Given this list of marker genes DUSP10, COL4A4, TRIM45, ADCY6, TTLL7, TIPIN, NCOA7, PLCXD1, MSH2, TCEAL9, E2F2 (E2F transcription factor 2, NCBI Gene Id 1870), SVIP, CLSPN, INSR, ABCA5, ZBTB14, PRIM1, RGS7, MCM10, C1GALT1, RFC2, EZH2, IVNS1ABP (NCBI Gene Id 51489), RECQL4, TOPBP1, CCN2, PCNA, NR4A3, CDC25A, H3C2, CNNM3, H4C5, DLGAP1, OSBPL6, ATAD2, TNS2, MSH6, DTL, CDT1, TLR3, PTGS2, PLSCR4, DNAJC6, PANK2, CCNE2, ACYP1, DNAJC3, RPA2, WDR76, MNS1, E2F1, DCLRE1A (DNA cross-link repair 1A), CDH24, RAD51, RABIF, SLC25A27, OSGIN2, GK, ZNF367, RRM2, MNX1, MNT, MDM1, ZMYND19, RBBP8, LIPH, MCM2, MBNL2, H2BC4, RFXAP, POLE, YEATS4, TENM3, MCM3, NEDD9, SPIN3 (NCBI Gene Id 169981), SMPD1, UBR7, MCM6, HSPB8, TCF19, RFC4, EAF2, POLE2, ARGLU1, FST, KLF5 (KLF transcription factor 5), ABHD10, CCNE1, FEN1, H4C4, AHI1, H2BC5, CASP8AP2, TMEM243, SSBP2, H4C2, OPCML, CHEK1, BRCA1, SLC38A2, MAGEL2, PEX13, E2F7, EXO1, CASP2, USP37, H2AC11, PASK, ARL6IP6, WDHD1, CHAF1B, GCLC, E2F8, NUDT7, DSCC1, H2AC6, AP3M2, BBX, RNPC3, FANCE, ICMT, OGT, ASPH, SLBP, NPAT, MAP2K6, CDC6, CDC7, BLM, PRKD1, FANCG, SP1, ZRANB2, H2AC20, H2AC7, IGF1R, BRIP1, JUND, MYB, TAF15, USP1, PAQR4, FAM111B, CENPQ, H2AC21, CTPS1, CCN1, H2AC25, UNG, CDH10, H2AC17, MATN1, CHAF1A, TXNRD1, MASTL, ADAMTS1, PEX11B, AKAP5, TIFA, MAN1A2, GMNN, ANKRA2, POLA2, INSIG2, CDCA7, TLR6, AMIGO2, H4C8, KLRK1, BARD1, GINS2, RIMKLB, REEP1, TCIM, POLD3, DCLRE1B, USP53, TMCC1, TREX1, MCM5, HELLS, TP53INP1, ANK3, H2AC12, GLCCI1, LCMT2, MSH5-SAPCD1, H2BC21, MRC2, MITF, FOSB, ABHD4, NASP, USP18, H2BC13, RMI1, ARID5B, ADCK2, CCND3, here is a description of the gene set: from publication Fischer M, Grossmann P, Padi M, DeCaprio JA (PMID 27280975) Cell cycle genes with peak expression in G1/S check point. studied in species Homo sapiens Cell cycle genes with a CC Expression Score <= -2 (identified in at least 2 genome-wide cell cycle gene expression profiles with peak expression in G1/S) Human Gene Set: FISCHER_G1_S_CELL_CYCLE